The following is a description of a gene set: studied in species Mus musculus An intracellular signaling cassette in which a small monomeric GTPase of the Rap subfamily relays a signal. Mouse Gene Set: GOBP_RAP_PROTEIN_SIGNAL_TRANSDUCTION, and this is the list of marker genes: Cbl, Sgsm3, Rap1a, Plk2, Timp2, Rap2b, Rap2c, Rap1b, Kif14, Rap2a, Gm266, Rdx (radixin), Rapgef2, Rapgef1, Rapgef3